The following is a description of a gene set: The aggregation, arrangement and bonding together of proteins and a snoRNA to form a small nucleolar ribonucleoprotein (snoRNP) complex. studied in species Mus musculus Mouse Gene Set: GOBP_SMALL_NUCLEOLAR_RIBONUCLEOPROTEIN_COMPLEX_ASSEMBLY, and this is the list of marker genes: Znhit3, Znhit6, Snu13, Nufip1, Naf1, Ruvbl1, Shq1, Nopchap1, Taf9, Ruvbl2, Pih1d2, Pih1d1